The following is a description of a gene set: studied in species Homo sapiens Expression profiling of Rag2-deficient Ets1++ and Rag2-deficient Ets1-- mature NK cells and WT bone marrow progenitors, WT T cells, and WT Pro B cells Human Gene Set: GSE37301_HEMATOPOIETIC_STEM_CELL_VS_RAG2_KO_NK_CELL_UP from publication Ramirez K, Chandler KJ, Spaulding C, Zandi S, Sigvardsson M, Graves BJ, Kee BL (PMID 22608498) Genes up-regulated in hematopoietic stem cells versus NK cells with RAG2 knockout., and this is the list of marker genes: LAIR1, VPS45, ZMYND8, PSMB10, IFI35, LAD1, RBM38, SNAI2, BCL9L, RAPGEF4, SLC37A1, DGKA, TESC, CD3D, SAAL1, OASL, RMDN3, C1QBP, PGPEP1L, FGF13, RAPGEF6, PRKCQ, ZBTB37, GRAP2, RGS9, SUV39H1, CCT5, DOCK4, IDH2, ADD3, PRKCH, PFAS, FAS, KLF3, TMCO4, TANC1, PDCD2, AS3MT, RASSF2, TNFSF8, DNAI4, BAIAP3, NRARP, ETV3, VANGL2, SPSB1, SH2D1A, PVR, SLC26A11, PIP4K2A, SRSF10, PCBD2, ISOC1, CARMIL2, ATRNL1, KCNA2, PLXNA3, GABRR2, PRRG1, CD101, NCF1, WDR59, HDAC1, TIMM44, MARCHF3, CNN3, DAPL1 (NCBI Gene Id 92196), RBCK1, POFUT1, HNRNPH3, PACSIN1, CAND2, CACYBP, RBM45, DNAAF5, ZC3H12D, ZZZ3, TERT, TARS2, EME2, PDE7A, STAMBPL1, BANK1, TGFBR3, PIGC, CHST15, FRMD8, SSBP2, AKAP8, PAFAH1B3, LEF1, FEM1A, F2RL1, TRUB2, NDUFA4, SS18, CYP2R1, RIPOR2, ARID5A, GTF3C2, TRIB2, HDHD5, FOXO1, SLC14A1, WDR82, ESR1, STARD3, FTSJ3, IL6R, LTB, PIK3R3, SPEF2, LIMK1, SNORA52, TNIP1, ASAP1, FAM3C, RALGPS1, PIK3CD, ADH1A, SLC17A9, TWSG1, KCNH2, CARD6 (caspase recruitment domain family member 6), PDE4B (NCBI Gene Id 5142), NACA, TCF20, SMC4, PTPN6, ARMCX2, RCCD1, ARHGEF1, TIMM10, AGFG1 (ArfGAP with FG repeats 1), BCL2L11, SIPA1L1, ECM1, ANGEL2, ITM2A, KBTBD11, SOX4, ATP1B1, EXT1, PARP11, SH3KBP1, FOXP1, PDLIM1, MYH9, PECAM1, PARP8, ZFP3, TBC1D4, MLLT3, INPP5F, CYRIA, USP24, RCN1, ABLIM1, RPL3, GBP5, SATB1, SEPTIN6, NIN, SLC44A2, ABTB2, AFF3, AP4B1, PRPF31, SPRED1, ABRAXAS1, SESN3, CYTH3, STAT1 (signal transducer and activator of transcription 1), KAT2A